Given this list of marker genes F11 (coagulation factor XI), F9, KNG1 (NCBI Gene Id 589), GP1BB, GP9, GP5, KLKB1, F12, GP1BA, here is a description of the gene set: species: Homo sapiens Activated factor FXII (FXIIa) promotes fibrin clot formation by converting FXI to FXIa (Cheng Q et al., 2010), while plasma kallikrein directly binds and activates FIX (Kearney KJ et al., 2021), thereby facilitating crosstalk between coagulation and inflammation. Despite this, both FXII and plasma kallikrein are non-essential for normal hemostatic pathway, as individuals deficient in FXII or prekallikrein do not exhibit bleeding disorders (Kokoye Y et al., 2016). At the same time, studies using animal disease models suggest that these factors may contribute to thrombotic events under pathological conditions (Revenko AS et al., 2011; Matafonov A et al., 2014; reviewed by Schmaier A, 2016). Deficiencies of FXII, prekallikrein (PK), high molecular weight kininogen (HK), and the bradykinin B2 receptor are associated with prolonged thrombin generation times in murine models of arterial and venous thrombosis (Pauer HU et al., 2004, Stavrou EV et al., 2015, Merkulov S et al., 2008, Shariat-Madar Z et al., 2006; Fang C et al., 2013). Alternatively, FXI null mice exhibit a bleeding phenotype, whereas prolylcarboxypeptidase- and C1 inhibitor-deficient mice display a prothrombotic phenotype (Gailani D et al., Adams GA et al., 2011; Grover S et al., 2023). Large population studies indicate that FXII deficiency protects against venous thrombosis, whereas C1 inhibitor deficiency is associated with increased thrombotic risk (Haj AK et al., 2025; Rodriguez Espada A et al., 2026). Reactome Pathway: FXIIa, PKa-dependent activation of coagulation pathway part of: Regulation of clotting cascade